The following is a description of a gene set: Human Gene Set: HP_FIBROSARCOMA studied in species Homo sapiens Fibrosarcoma A fibroblastic sarcoma is a malignant tumor derived from fibrous connective tissue and characterized by immature proliferating fibroblasts or undifferentiated anaplastic spindle cells., and this is the list of marker genes: FOXC2, COL1A1, PDGFB, APC, MTAP